Given this list of marker genes BAP1, TRAF7, SBDS, DLL1, CDH23, SMARCB1, PDGFB, RBM28, BTK, TBX2, CCDC141, ZNRF3, LEP, STAG2, CDKN2A, DISP1, ADAT3, YY1, PITX2, VPS13B, CHD7, RRM2B, SRD5A3, SMO, FGFR1, TBX19, GRM7, LIG4, SOX11, MT-TL1, FSHB, POU3F4, DNAJC21, TBCE, MAP2K2, CTSK, IGF2, ALX3, CRIPTO, KDM6A, HID1, FGF8, FGF17, WDR4, SNORD116-1, APOA5, LHX4, NDNF, NODAL, SPRY4, MKRN3, FARSA, GCNA, TGIF1, AKT1, SOX3, PROKR2, NFKB2, NSUN2, HBB, MANF, OCA2, HS6ST1, IGSF1, TMEM67, PTCH1, TBCK, FLRT3, LEPR, FOXA2, SEMA3A, TP63, FOXH1, KMT2D, TERT, SLC7A7, KIAA0753, HERC2, EFL1, BRAF, NDN, SMARCE1, MEN1, PSMD12, NKX2-1, SOX10, CDON, POLE, TSHB, POMC, PNPLA6, FANCF, PWAR1, IARS2, THOC2, PWRN1, GNB2, IL17RD, EDA2R, RRAS2, PIK3CA, GAS1, MPDU1, ARNT2, KMT2A (NCBI Gene Id 79951), CDKN1C, CTNNB1, WDR11, PROP1, EIF2S3, SMC1A, MT-ATP8, DYRK1A, DUSP6, GRB10, ACP5, SEMA3E, ALMS1, EDA, TMCO1, PUS1, SLC29A3, TP53, TAF4B, KANSL1, CEP57, TRHR, GHSR, ANOS1, DCC, SIN3A, SNORD115-1, DBH (dopamine beta-hydroxylase), ESCO2, OTX2, SIX3, GLI3, B3GLCT, BPTF, BMP4, SUFU, FEZF1, GMNN, SNRPN, GH1, GNAS, TACR3, PLCH1, AIP, LHX3, BRCC3, ADNP, IKBKG, ZIC2, HESX1, NFKBIA, ZNF148, RFWD3, WASHC5, KATNIP, GHRHR, NF2, POLR3A, PROK2, PREPL, GLI2, ZMYND15, RNF113A, STIL, PCSK1, ZNF462, GPR101, POU1F1, STAT5B, STX16 (syntaxin 16), PRKAR1A, SHH, FLNB, MADD, POLR3GL, NPAP1, ZSWIM6, RNPC3, MAGEL2, AFF4, here is a description of the gene set: Human Gene Set: HP_HYPOPITUITARISM studied in species Homo sapiens Hypopituitarism